Given this list of marker genes NID2, CLEC2B, QKI, MT1G, CDH6, PLAGL1, HLA-F, SRGN, PTN, TPST2, PLAT, MTSS1, MAF, PSMB9, CASP1, MAB21L2, PTPRK, SH3KBP1, MRPS6, UCK2, KHDRBS3, PHLDA2, NR2F2, PREX1, GPR84, UPP1, MECOM, NOCT, ELOA, MARCHF3, TSPAN5, CD44, TREX1, LYRM2, HMGA2, HNRNPH1, AIM2, TCIRG1, PPP1R14C, ACSL5, FAM156A, HECW2, SZRD1, HMOX1, NUP88, GTSF1, HOXA10, TUBB2A, DUSP6, SATB2, HLA-J, SOCS2, ALYREF, HLA-B, MARCKSL1, NAP1L1, PPP4R1, MAP3K5, LRP8, TFAP2A, STAMBPL1, HOXA11, PRKAR1A, LYN, PSMB8, COTL1, ADORA2B, FOSL1, SERPINI1, LMNA, LAP3, C15orf48, MT1X, BTN3A3, NEK6, MT2A, HAS2, EML1, ARHGAP24, SNX8, FHOD1, SERP2, PTGR1, ORAI1, ABCB1, GMDS, ENO3, DHRS7, HPCAL1, NETO1, CHN1, KYNU, NTM, PAICS, JAG1, BMI1, SH3TC1, TP53I3, PSMB10, AIFM2 (NCBI Gene Id 84883), SERPINB1, PDXK, PDGFA, PHACTR2, MAPRE2, GNB1, HOMER3, TBC1D1, RAB31, PTBP3, ABCB4, VEGFA, NQO1, MT1F, ODC1, GOLIM4, IRX5, CHST15 (NCBI Gene Id 9916), ARL4C, CELF1, SLC41A1, ITM2C, DDX39A, SLC7A11 (NCBI Gene Id 23657), ETS1, AGA, GAP43, GSDME, here is a description of the gene set: studied in species Homo sapiens Genes up-regulated in adipose tissue mesenchymal stem cells (ASC) vs bone marrow mesenchymal stem cells (rBMSC) Human Gene Set: IZADPANAH_STEM_CELL_ADIPOSE_VS_BONE_UP from publication Izadpanah R, Kaushal D, Kriedt C, Tsien F, Patel B, Dufour J, Bunnell BA (PMID 18519682) Mesenchymal stem cells (MSC) derived from bone marrow stem cells (BMSC) and adipose tissue stem cells (ASC) of humans and rhesus macaques were evaluated for their cell cycle properties during protracted culture in vitro. Human ASCs (hASC) and rhesus BMSCs (rBMSC) underwent significantly more total population doublings than human BMSCs (hBMSC) and rhesus ASCs (rASC). The cell cycle profile of all MSCs was altered as cultures aged. hMSCs underwent an increase in the frequency of cells in the S phase at P20 and P30. However, rhesus MSCs from both sources developed a distinct polyploid population of cells at P20, which progressed to aneuploidy by P30. Karyotype analysis of MSCs revealed the development of tetraploid or aneuploid karyotypes in the rhesus cells at P20 or P30. Analysis of the transcriptome of the MSCs from early and late passages revealed significant alterations in the patterns of gene expression (8.8% of the genes were differentially expressed in hBMSCs versus hASCs, and 5.5% in rBMSCs versus rASCs). Gene expression changes were much less evident within the same cell type as aging occurred (0.7% in hMSCs and 0.9% in rMSC). Gene ontology analysis showed that functions involved in protein catabolism and regulation of pol II transcription were overrepresented in rASCs, whereas the regulation of I kappa B/nuclear factor-kappaB cascade were overrepresented in hBMSCs. Functional analysis of genes that were differentially expressed in rASCs and hBMSCs revealed that pathways involved in cell cycle, cell cycle checkpoints, protein-ubiquitination, and apoptosis were altered.